The following is a description of a gene set: SUMOylation of DNA replication proteins studied in species Mus musculus Mouse Gene Set: REACTOME_SUMOYLATION_OF_DNA_REPLICATION_PROTEINS, and this is the list of marker genes: Aaas, Nup54, Nup88, Top2b, Nup107, Top1, Nup42, Nup205, Pcna, Nup37, Nup85, Tpr, Nup58, Nup43, Sumo2, Nup98, Sumo1, Aurkb, Ranbp2, Pom121, Nup50, Nup35, Pias3, Pias4, Nup188, Cdca8, Nup214, Nup160, Nup93, Nup153, Rae1, Nup210, Sumo3, Nup133, Nup155, Seh1l, Incenp, Nup62, Top2a, Ube2i, Ndc1, Rangap1 (RAN GTPase activating protein 1)